The following is a description of a gene set: part of: SLC-mediated transmembrane transport Reactome Pathway: Cellular hexose transport species: Mus musculus electronically inferred by orthology from the curated human pathway This event has been computationally inferred from an event that has been demonstrated in another species.<p>The inference is based on the homology mapping from PANTHER. Briefly, reactions for which all involved PhysicalEntities (in input, output and catalyst) have a mapped orthologue/paralogue (for complexes at least 75% of components must have a mapping) are inferred to the other species., and this is the list of marker genes: Slc5a9, Slc2a1, Slc2a6, Slc2a12, Slc5a4a (solute carrier family 5, member 4a), Slc50a1, Mfsd4b4, Slc2a8 (NCBI Gene Id 56017), Fgf21, Slc2a4, Slc5a2